The following is a description of a gene set: species: Homo sapiens Human Gene Set: GOBP_CELLULAR_RESPONSE_TO_ACIDIC_PH Any process that results in a change in state or activity of a cell (in terms of movement, secretion, enzyme production, gene expression, etc.) as a result of a pH stimulus with pH < 7. pH is a measure of the acidity or basicity of an aqueous solution., and this is the list of marker genes: SLC9A1, GPR4, SCNN1G, TRPV1, GPR68, CHP1 (NCBI Gene Id 11261), SCNN1A, KCNK3, PKD2L1, KCNK1, RAB11B, RAB11FIP5, PKD1L3, GPR65, KCNK4, SCNN1B, KCNK9 (NCBI Gene Id 51305), SCNN1D, ASIC2